The following is a description of a gene set: Human Gene Set: GOBP_PYRUVATE_METABOLIC_PROCESS The chemical reactions and pathways involving pyruvate, 2-oxopropanoate. species: Homo sapiens, and this is the list of marker genes: OGDHL, PRKAA2, GCK, ADPGK, SLC4A4, GAPDH, ENO3, PFKM (NCBI Gene Id 5215), PKLR, PFKL, PRKAG2, HIF1A, HKDC1, ALDOC, PPARA, LDHAL6B, FOXK2, PGK1, LDHA, MFSD8, PGK2, INSR, ARL2, BPGM, EP300, TRIM63, SLC16A1, LDHC, COL6A1, ENO1, PRKAG3, PGAM2, OGDH, DLD, EIF6, ALDOB (NCBI Gene Id 229), SRC, MLXIPL, ME2, MTCH2, GAPDHS, PRKAG1, HTR2A, GALK1, PSEN1, ZBTB20, INS, DHTKD1, PDHA1, BCL2L13, SLC2A6, LDHAL6A, GPD1, NCOR1, PDK3, UCHL1, LIPA, HOGA1, LDHB, FLCN, PGAM4, PGM1, PCK1, MPC2, PRKACA, PCK2, RPTOR, IGF1, TIGAR, GPI, FKRP, P2RX7, NUPR1, IER3, ARNT, TPI1, HK3, IFNG, PRKAA1, KAT2B, APP, GIT1, HK2, ALDOA, DLAT, PDHX, HK1, PDK2, FAHD1, STAT3, PRXL2C, ENO2, PFKP, JMJD8, PFKFB3, OGT, DDIT4, UCP2, FOXK1, ZBTB7A, MLST8, PDK1, PFKFB1, PGAM1, FBP1, MTOR, PDK4, VDAC1, PDHB, PKM, ENO4 (NCBI Gene Id 414268), TREX1, ME1, PFKFB2, TPK1, SDS, PC (NCBI Gene Id 5091), PDHA2, CBFA2T3, SRR, SIRT6, PPP2CA, HDAC4, SLC16A3, BCKDK, SLC4A1, ME3, ACTN3